The following is a description of a gene set: Mouse Gene Set: chr2F3 species: Mus musculus, and this is the list of marker genes: Sel1l2, Rps19-ps7, Plcb1, Slx4ip, Ankef1, Flrt3, Gm14210, Jag1, Gm14061, Gm14066, Ism1, Ndufaf5, Plcb4, Zcchc9-ps, Tasp1, Gm14056, Gm25583 (predicted gene, 25583), Gm14062, Gm14064, Gm14038, Gm14211, Gm14065, Gm14037, Gm14036, Gm14055, Mkks, Lamp5, Snap25, Esf1, Sptlc3, Gm14071, Macrod2, Pak5, Gm14053, Gm26227, Platr3, Gm14054, 4930545L23Rik, Gm14218, 9630028H03Rik, Mir1952, Macrod2os2, Btbd3